Given this list of marker genes Fundc1, Ppfibp2, Fadd (Fas associated via death domain), Decr2, Ppp1r1b, Dhx58, Tsg101, Tjp3, Coro2a, Cblc, Enpp4, Pkn1, Golph3l, Klhl5, Nup37, Tom1, Ppa2, Nat2, Glul, Chchd5, Iqgap2, Lyplal1, Adat1, Erlin2, Tst, Rer1, Arhgef16, Hagh, Plekhg3, Sorbs2, Sepsecs, Lgals3bp, Plpp2, Pafah1b3, Hpn, Map3k1, Neu1, Ehhadh, Thumpd3, Arrdc4, Prlr, Nectin4, Car2, Creb3l4, Gatb, Stxbp2, Isg20, Ctps2, Epcam, Ppl, Slc25a35, Cmc1, Casz1, Sgsm3, Nhlrc3, Cgnl1, Hdhd3, Lrba, Ltf, Reep6, Tnf, Cgn, Psme1, Ccng1, Dera, Dennd11, Rbm47, Arpc1a, Smim1, Zfp3, Asb8, Arrdc1, Tmem125, Stx8, Trappc6a, Wfdc2, Syngr1, Hlcs, Arfgef3, Myo5b, Gstk1, Nhsl3 (NCBI Gene Id 97130), Acad10, Slc39a9, Gipc1, Ift43, Ceacam1, Mlph, Slc5a6, Ica1 (NCBI Gene Id 15893), Capg, Mapk13, Fbxo6, Cldn3, Rad51d, Faah, Abhd11, Ifi35, P2rx4, Acot4, Tmem158, Mif4gd, Acy1, Barx2, Zfand2b, Cxcl17, Mrpl9 (NCBI Gene Id 99489), Tmem9b, Ssh3, Mboat1 (membrane bound O-acyltransferase domain containing 1), Ifngr2, Snx14, Tdrkh, Oplah, Dhcr24, Tgm2, Snx15, Rmdn3, Lars1 (leucyl-tRNA synthetase 1), Rhpn2, Pnpo, Elf3, 2610528J11Rik, Bcl3, Homer2, AU022252 (NCBI Gene Id 230696), Fntb, Nipsnap3b, Paox, Nudt2, Mansc1, Rnf135, St14, Cd14, Kynu, Tom1l1, Myh14, Tmem128, Tmem41a, Cct6b, Crb3, Evpl, Dennd2d, Tram1, Shmt1, Slc35d2, AU040320, Slc5a1, Vipr1, Mvp, Cpt2, Ibtk, Kif1b, Pxylp1 (2-phosphoxylose phosphatase 1), Rabgap1 (RAB GTPase activating protein 1), Aldh3b2, Ano9 (anoctamin 9), Mta3, Nipsnap2, Vtcn1, Golm1, Slc44a4 (solute carrier family 44, member 4), Pyroxd2, Edem2, Cd24a, Grb7 (NCBI Gene Id 268479), Htatip2, Tnfaip2, Osbpl10, Tm7sf2, Sorl1, Ankra2, Mapk9, Tmem135, Mboat2, Pi4k2b (phosphatidylinositol 4-kinase type 2 beta, NCBI Gene Id 74082), Gle1, Armt1, Slc22a18, Tbc1d8, Ptbp3, Pomt1, Gm5617, Ralgps1, Stap2, Os9 (NCBI Gene Id 77051), Wnk4, Atp6v0e2, Hcar2, Sigirr (single immunoglobulin and toll-interleukin 1 receptor (TIR) domain), Vill, Unc93b1, Tia1, Zswim4, Pigo (NCBI Gene Id 56703), Pcbd2, Dclre1c, Anxa7, Mtus1, Foxa1, Acot13, Klf6, Ap1g2, Lypd3, Lsr, Slc35a3, Rab11fip4, Baiap2l1, Esr1, Dhrs4, Tango2, Bola1, Snap29, Gale, Get1, Elapor1, Psmd10, Serinc3, Ivd, Sulf2, Snx10, Snrnp35, Sdsl, Dhx32, Sirt5, Tirap, Tlcd4, Pgap3, Myo5c, Plpp6, Thnsl2, Sult2b1, Spint1, Tk2, Ptpn6, Tlr3, Rnf130, Herc4 (hect domain and RLD 4), Tmc4, Cacfd1, Bdh1, Prag1 (PEAK1 related kinase activating pseudokinase 1), Dnajc12, Cmas, Hid1, Sqor, Tuft1, Cldn8 (claudin 8), Pgap2, Oxld1, Elmo3, Fam221a, Tmprss2, Rhbdd2, Hdac10, Slc16a5, Cdk19, Dlg3, 2310030G06Rik, Stat5a, Slc35a1, Abca3, Aldh5a1, Dbndd2, Rassf7, Alkbh6, Camsap3, Uros, Nherf1, Rrm2b, Slc10a7, Tspan17, Fam110a, Mpi, Atp6v1e1, Nudt1, C1galt1c1, Pacsin3, Akip1, Mccc2, Slc37a1, Fgf13, Snx8, Ap1m2, Marveld3, Prr13, Cib1, Mbtps2, Akap10, Rab25, Pak1, Rab11fip1, Tmem54, Psmb8, Bik, Sh3bp2, Atg2a, Rfx1, Pgd, Tpd52, Ido1, Tmed3, Rwdd3 (NCBI Gene Id 99697), Sil1, Acot8, Podxl, Zscan20 (NCBI Gene Id 277652), Gcc2, Add3, Klk11, Prkcz, Slc49a3, Batf (basic leucine zipper transcription factor, ATF-like), H2bc21, Ccdc125 (coiled-coil domain containing 125), Gata3, Pex11g, Alad, Tpcn1 (two pore channel 1), Trim68, Ell3, Coasy, Sdcbp2, Susd4 (NCBI Gene Id 98456), Tmem139, Abhd17c, Gca, Slc28a3, Zfp750 (NCBI Gene Id 319530), Zdhhc12, Epb41, Clcn3, Muc1, Rorc, Pdzk1ip1, Aldh1a3, Tmprss13, Dhcr7, Ndufa7, Frk, Atp1b1, Hdac11, Dtx3l, Polb, Chpt1, Rnaseh2a, Tfcp2l1, Cracr2b, Cldn1, Grtp1, Mb, Gsto2, Ppm1h, Stard10, Dmbt1, Scyl3, Ide, Sytl4, Vrk3, Slc46a3, Spata13, Tfap2a, Cldn7, Tlr5, Rreb1, Zdhhc24, Ptprf (protein tyrosine phosphatase receptor type F), Tmem181a, H2aj, Erbb3, Zfp524 (zinc finger protein 524), Orai1, Bcl2l13, Sfxn1, Lrrc26, Dapp1, Bnipl, Snorc (secondary ossification center associated regulator of chondrocyte maturation), Slc39a11, Tspan33, Zfp334, Cdh1, Sidt1, 6030458C11Rik, Tpp1, Shtn1, Ildr1, Tcirg1, Alg8, Rpl22, Ngef, Rab5b, Ap3s2, Krt19 (keratin 19), Pxmp2 (NCBI Gene Id 19301), Btc, Cobl, Spdef, Liph, Rab3ip, Grhl1, Erbb2, Ncoa2, Krt18, Rnaseh2b, Gjb2, Ndufv3, Mrps21, Mtif2, Gabrp, Stat6, Cldn4, Wdr31, Nup210, Tmem62, Krt8, here is a description of the gene set: INTRODUCTION: Molecular characterization of the normal epithelial cell types that reside in the mammary gland is an important step toward understanding pathways that regulate self-renewal, lineage commitment, and differentiation along the hierarchy. Here we determined the gene expression signatures of four distinct subpopulations isolated from the mouse mammary gland. The epithelial cell signatures were used to interrogate mouse models of mammary tumorigenesis and to compare with their normal human counterpart subsets to identify conserved genes and networks.METHODS: RNA was prepared from freshly sorted mouse mammary cell subpopulations (mammary stem cell (MaSC)-enriched, committed luminal progenitor, mature luminal and stromal cell) and used for gene expression profiling analysis on the Illumina platform. Gene signatures were derived and compared with those previously reported for the analogous normal human mammary cell subpopulations. The mouse and human epithelial subset signatures were then subjected to Ingenuity Pathway Analysis (IPA) to identify conserved pathways.RESULTS: The four mouse mammary cell subpopulations exhibited distinct gene signatures. Comparison of these signatures with the molecular profiles of different mouse models of mammary tumorigenesis revealed that tumors arising in MMTV-Wnt-1 and p53-/- mice were enriched for MaSC-subset genes, whereas the gene profiles of MMTV-Neu and MMTV-PyMT tumors were most concordant with the luminal progenitor cell signature. Comparison of the mouse mammary epithelial cell signatures with their human counterparts revealed substantial conservation of genes, whereas IPA highlighted a number of conserved pathways in the three epithelial subsets.CONCLUSIONS: The conservation of genes and pathways across species further validates the use of the mouse as a model to study mammary gland development and highlights pathways that are likely to govern cell-fate decisions and differentiation. It is noteworthy that many of the conserved genes in the MaSC population have been considered as epithelial-mesenchymal transition (EMT) signature genes. Therefore, the expression of these genes in tumor cells may reflect basal epithelial cell characteristics and not necessarily cells that have undergone an EMT. Comparative analyses of normal mouse epithelial subsets with murine tumor models have implicated distinct cell types in contributing to tumorigenesis in the different models. from publication Lim E, Wu D, Pal B, Bouras T, Asselin-Labat ML, Vaillant F, Yagita H, Lindeman GJ, Smyth GK, Visvader JE (PMID 20346151) Genes consistently down-regulated in mammary stem cells both in mouse and human species. studied in species Mus musculus Mouse Gene Set: LIM_MAMMARY_STEM_CELL_DN